Given this list of marker genes Slc29a4, Gck, Vip, Cartpt, Ptgs1 (prostaglandin-endoperoxide synthase 1), Crhr2, Ly6e, Crhr1, Gabbr1, Slc22a3, Slc22a1, Crh, Slc22a2, here is a description of the gene set: The directed movement of epinephrine into, out of or within a cell, or between cells, by means of some agent such as a transporter or pore. studied in species Mus musculus Mouse Gene Set: GOBP_EPINEPHRINE_TRANSPORT